The following is a description of a gene set: studied in species Homo sapiens Genes having at least one occurrence of the motif TTTSGCGSG in the regions spanning 4 kb centered on their transcription starting sites. This matches the E2F, TFDP1 transcription factor binding site V$E2F_Q3_01 (v7.4 TRANSFAC). Human Gene Set: E2F_Q3_01, and this is the list of marker genes: CDC45, ELAVL2, CDC20B, TIPIN, PRRC2C, SIN3A, ZMYM2, MCM7, MCM3, SMC3, RFC1, PRMT3, EPHB1, MYC, EZH2, CBX5, MAZ, EVA1B, PIM1 (Pim-1 proto-oncogene, serine/threonine kinase), THAP8, HMGA1, SERBP1, SMC2 (NCBI Gene Id 10592), ZNF362, ZDHHC17, DHX40, CDC6, MCM6, PELP1, TOPBP1, BRMS1L, HNRNPD, PCSK1, GINS3, CTCF, RAD51, YWHAQ, PELO, EGR3, SSU72, H2BC10, MEIS2, CDCA7, IER5L, FBXL20, E2F7, E2F8, TLE4, CTDSPL2, ING3, TOP1, RALY, PPRC1, PIK3R4, ASXL2, ZNF367, DNMT1, HOXA9, ARHGAP11A, INSM1, STAG2 (NCBI Gene Id 10735), RHD, H1-3, HOXC10, KBTBD7, TRMT2A, NUP155, GEN1, CITED2, SREK1, TMEM187, CSRNP1, OSBPL7, LRTOMT, PTMA, YBX2, PODN, PRKDC, USP49, DCK, NUMA1, SKIDA1, NEGR1, SIK2, SRSF2, FANCG, TRMT13, UNG, H2BC12, MCM8, PIK3R3, PPP1R8, GMNN (NCBI Gene Id 51053), SMG1, TRMT6, MTF2, PPP1R9B, NECTIN1, PKMYT1, PAN2 (poly(A) specific ribonuclease subunit PAN2), FBXO9, SLC38A1, MELK, NR3C2, ERBIN, MXD3, USP2, CDC25A, DCLRE1A, KCNA6, ID3, UXT, HNRNPA1, ANKHD1-EIF4EBP3, IPO7, TNPO2, NCOA6, RANBP1, ZNF565, SMC6, GPAT2, SLC16A2, BMP7, POLA2, DAXX, NHLRC2, DDX17, UFD1, STK35, KPNB1, E2F3, EIF3K, AGFG2, PCYT2, PCDH7, ATP5MC2, SEMA5A, STT3B, ARHGAP6, RELT, MCM2, NCL, DNAJC11, OTUD7B, SMAD6, NDUFA11, DNAJC5G, KLF5, TBX6, SUV39H1, RIBC1, TBC1D31, SRSF1, GATA3, DMD, ARID4A, RPS6KA5, ATAD2, PCLAF (NCBI Gene Id 9768), SASS6, POLE4, GPN3 (GPN-loop GTPase 3), POLA1, TRIM47, RTF1, CASP2, RPS19, TMEM131L, TBX3, HMGN2, ZCCHC8, CDK1 (NCBI Gene Id 983), DDB2, ACBD6, SALL1, H2AZ1, ITGA1, ZNF687, PCNA, AP4M1 (adaptor related protein complex 4 subunit mu 1), NUP153 (NCBI Gene Id 9972), FHIP1B, KDM3A, USP1, ANKHD1, WEE1, MAP4K1, GLRA3, SMC1A (NCBI Gene Id 8243), H2AC12, ARHGAP36, NIPBL, OVOL2, NSD3, GAPDH, PRPS1, STMN1, NRP2, ATE1, STAG1, E2F1, RHCE, SLC6A4, FANCC (NCBI Gene Id 2176), FMO4 (NCBI Gene Id 2329), CASP8AP2, PHF13, PATZ1, DOLK, MCM4, JPH1, PIAS1, INTS7, FAM216A, PAQR4, ERF, DCTPP1, CHGB, DLST, JADE2 (jade family PHD finger 2), PDS5B, KMT5A, WDR62, ADAMTS2, POLE2, FBXO5, NFATC2IP, UCHL1, HS6ST3, RAB11B, JADE1, LUC7L3, CTNND2, NASP, KCND2, DMRT1